The following is a description of a gene set: Human Gene Set: REACTOME_LYSOSPHINGOLIPID_AND_LPA_RECEPTORS studied in species Homo sapiens Lysosphingolipid and LPA receptors, and this is the list of marker genes: S1PR2, S1PR4, PLPPR3, PLPPR5, PLPPR1, LPAR2, LPAR1, LPAR5, S1PR3, LPAR3, PLPPR2, S1PR1 (sphingosine-1-phosphate receptor 1), PLPPR4, S1PR5